The following is a description of a gene set: Transcription factors that regulate quiescence, proliferation, and homing of lymphocytes are critical for effective immune system function. In the present study, we demonstrated that the transcription factor ELF4 directly activates the tumor suppressor KLF4 downstream of T cell receptor (TCR) signaling to induce cell cycle arrest in naive CD8+ T cells. Elf4- and Klf4-deficient mice accumulated CD8+CD44hi T cells during steady-state conditions and generated more memory T cells after immunization. The homeostatic expansion of CD8+CD44hi T cells in Elf4-null mice resulted in a redistribution of cells to non-lymphoid tissue due to reduced expression of the transcription factor KLF2, and the surface proteins CCR7 and CD62L. This work describes the combinatorial role of lymphocyte-intrinsic factors in the control of T cell homeostasis, activation and homing. Human Gene Set: GSE15324_NAIVE_VS_ACTIVATED_CD8_TCELL_UP Genes up-regulated in comparison of naive CD8 T cells versus activated CD8 T cells. species: Homo sapiens from publication Yamada T, Park CS, Mamonkin M, Lacorazza HD (PMID 19412182), and this is the list of marker genes: CALHM6, ARSB, RPTN, SLC16A5, KHK, BCL9L, INPP4A, RFTN2, CHKB, USP18, NTRK3, TRAF5, MARCHF3, TNNI2, EEIG1, IFIT1B, FAHD2A, DEAF1, GAREM1, C11orf71, PKP3, SHLD1, TNFAIP8L1, RUSF1, VIPR1, SEPTIN1, SHD, PLPP4, MLYCD, ATP8B3, METAP1D, PHYHIPL, SLC47A1, CIITA, CMPK2, CFAP410, USF1, FPR3, DLL3, ITGAM, IFIT3, TSACC, DNTT, TCEAL1, HLA-DOA (NCBI Gene Id 51034), FBXL8, CCL7, IVD, PGAP6 (post-GPI attachment to proteins 6), GPR183, HLA-DQA1, HDHD5, FHIP1B, ODAD1, C1orf56, TBC1D17, VAMP1, OAS2, SHB, JUNB, CREBBP, PAQR7, ATP10D (ATPase phospholipid transporting 10D (putative)), BSDC1, SLC39A11, NBEAL2, SLC6A19, B3GAT3, UNC5CL, DAPK3, HAS3, PPARGC1B, PHKA1, ARID5B, CYP3A4, ANKRD12, DLGAP4, OCEL1, CD1D, RHBDD2, LIX1, MYO7A, MAP3K4, TTYH3, NOD1, SMAD7, HPGD, ST8SIA3, DNM2, POU4F1, FAM193B, MROH1, ABLIM2, AGAP2, RCN3, CLCN4, NIPAL1, IGHG1, ITPR3, ZNF830, KCNJ10, LRRC23, RESF1, ZNF628, FHIT, COQ10A, MAP3K14, KCNJ4, GLIPR1L2 (NCBI Gene Id 144321), L1TD1, ZBTB42, RUSC2, OAZ2, RNASEK, TOMM40L, DSTYK, CCL25, C11orf68, ANXA13, SUSD3, GLIS3, GPATCH2, ADAM22, LDHD, RNF32, ZFP14, FBXL12, NRAP, XAF1, IGLL1, ST3GAL1, TRAPPC14, FEM1A, SLC25A44, CEP126, GABRD, LBP, SEMA4B, ZBTB10, CD40, CARNS1, GLB1L3, TMEM42, MN1, PNOC, PCNX1, KMT5B, ST6GALNAC5, HSD17B8, UBL5, CBLIF, ZNFX1, HCK, VPS33B (NCBI Gene Id 55513), ZBTB11-AS1, HMCES, BLVRB, TMEM119, TPGS1, CNGA1, FKBPL (FKBP prolyl isomerase like), DTNA, SLC25A29, CCL5, STAU1, IGFLR1, ACAD10, KMT2C, SLC45A4 (NCBI Gene Id 57210), EVX1, DEDD2, NFIA, USP21, VPS9D1, EPCIP, ACVR1B, SMG9, CLDN19, RIN3, CD19, COL7A1, BAIAP3, THUMPD2, ACVR2B, TNIP1, HMX2, SYDE1, ALOX5AP, SIK1, ZNF227 (NCBI Gene Id 7770), SERTAD1, TTF1, SNAI3-AS1, FOSB, SERPINF2 (serpin family F member 2), GZMK, HSCB, GPR34, BORCS8, SYTL2